The following is a description of a gene set: species: Homo sapiens Human Gene Set: AIZARANI_LIVER_C14_HEPATOCYTES_2 from publication Aizarani N, Saviano A, Sagar, Mailly L, Durand S, Herman JS, Pessaux P, Baumert TF, Grün D (PMID 31292543), and this is the list of marker genes: SERPINF2, CRP, APOA2, TF, MT1E, MT1H, TDO2, ADH4, ATP5PF, ACSM2A, CFHR3, SAA2 (serum amyloid A2), CYP27A1, CYP2D6, APOC1, ETFB, SCD, CYP8B1, A1BG, C4BPA, IGF2, SERPINA1, QDPR, SELENBP1, ALDH1A1, RARRES2, MT1F, SLC10A1, SULT2A1, AKR1C4, HP, SERPINA3, ASS1, CPS1, GC, MPST, RGN, AGXT, LBP, GADD45G, GATM, SLC27A5, PBLD, SDS, PTMS, CYB5A, C4BPB, LINC01554, ALDH1L1, FAH, CFHR1 (complement factor H related 1), ARG1, APOA1, VTN, SERPINA6, KNG1, TAT, NNMT, SHMT1, SERPIND1, APOB, HAAO, HAO2 (NCBI Gene Id 51544), ACSM5, C8A, CYP2C9, SORD (sorbitol dehydrogenase), F12, MT2A, RDH16, GJB1, ABHD14A-ACY1, EHHADH, HRG, PRAP1, SCP2, HPN, ITIH3, ALDOB, LDHA, ALAS1, C1S (complement C1s), PHYH, SERPINF1, GPX2, ADH6, UGT2B7, GPT2, APOH, GSTA2, APOC4-APOC2, FGB, DCXR, APOC4, CYP3A4, HSD17B6, AHSG, C1R, IGFBP1, SERPINC1, PRG4, FTCD, GLYAT, PLA2G2A, DPYS, HAMP, CLU (clusterin, NCBI Gene Id 1191), HMGCS2, APOE, RIDA, SMIM14, TMEM176A, LECT2, UQCRQ, FABP1, CYP4A11, ANGPTL3, A1CF, MT1G, ANG, CP, NIPSNAP1, FMO3, FGG, FBP1, AZGP1, IFITM3, HULC, BAAT, ACAA2, CYP4F3 (NCBI Gene Id 89256), AKR1D1, BNIP3, TTR, PRDX6, SPP2, RBP4, AFM, APOC3, HPX, C2, PTP4A1, ACAT1 (acetyl-CoA acetyltransferase 1), ITIH1, GLYATL1, C9, ALDH2, EPHX1, MGST1, QPRT, TMEM176B, SAA1, SOD1, F9, PLG, CES1, AMBP (alpha-1-microglobulin/bikunin precursor), REEP6, APOA5, ALDH8A1, SERPING1, GRHPR, FGA, ATF5, INSIG1, SLC22A1, SAA4, ECHS1, HPR, ALDH4A1, SERPINA11, F2, CYP1A2, APOM (NCBI Gene Id 55937), RBP5, FTL, HPD, ALDH6A1, CYP2B6, MLXIPL, C8B, IGFBP4, MPC1, PON3, APCS, LRG1, TST, GAMT, CYP2E1, ASGR1, ABAT (NCBI Gene Id 731754), PEBP1, CFB, UGT2B10, ADH1A, BHMT, ADH1B, HAO1, CFH, ASGR2, CPN2, CMBL, FGL1, PTGR1, CYP2A13, GSTA1, MST1, PON1, MT1X, HGD, PCK1, MAT1A, CYP2C8, GPX3, C3, LEAP2, ORM2, TLCD4, BHMT2, PLIN2, MTHFS, ORM1, ADI1, CRYL1, PCBD1, PIPOX